The following is a description of a gene set: species: Mus musculus Genes predicted to be targets of miRBase v22 microRNA mmu_miR_190b_3p in miRDB v6.0 with MirTarget v4 prediction scores > 80 (high confidence targets). Mouse Gene Set: MIR_190B_3P from publication Chen Y, Wang X (PMID 31504780), and this is the list of marker genes: Il13ra1, Slc38a2, Ammecr1, Nampt, Prps1l3, Nudcd2, Myef2, Phyhipl, Cdv3, Mapk1, P2ry6, Wdr48, Catsperg1, Dcaf1, Txlng, 4930480E11Rik, Bccip, Opcml, Pomk, Pabpc6, Manea, Zfp704, Marchf6, Alyreffm10, Adarb2, Klrc1, Rb1, Eps15l1, Itk, Clip4, Eapp, Mllt3, Eml2, Cdr2, Pdpk1, Prdm16, Matcap2, Zfp696 (zinc finger protein 696), Alyreffm17, Ankrd17, Gpr50, Faxc, Son, Zfyve26, Eif1b, Uba6, Kcng3, Myh10, Nfatc1, Unc5c, Foxp2, Nol4, Terf2, Alyreffm14, Alyreffm13, Rnf128, Rhobtb3, Sphkap, Magi3, Alyreffm15, Eml6, Shisa6, Alyreffm11, Smc2, Vps4b, Dph3, Ccng2, Smg1, Nsd3, Gm6377, Rai1, Tshz1, Ankrd44, Alyreffm16, B4galt1, Catsperg2, N4bp2l2, Cdhr1, Ankrd40, Sypl1, Cep135, Cntnap3